Given this list of marker genes NDUFB11 (NADH:ubiquinone oxidoreductase subunit B11), AKAP9, CACNA1S, TMEM43, SLC12A3, CPT2, SCN1B, RYR1, CALM2, SLMAP, GNAI2, SCN2B, CTNNA3, CASQ2, CACNB2, KCNJ8, KCNE3, TBX5, ACTC1, CACNA1C, GYG1, LMOD2, MYOZ2, SEMA3A, TECRL (NCBI Gene Id 253017), TPM1, TANGO2, SCN3B, JPH2, SLC25A20, KCNE5, CSRP3, SCNN1A, SCN10A, MYH7, SCN5A, NAA10, CALM3, DSG2, MYH6, GPD1L, TRDN, MT-CYB, NPPA, ABCC9, MYL2 (myosin light chain 2), HCN4, KCND3, CDH2, KCNJ5, BAG5, PPP1R13L, CACNA2D1, LMNA, CRELD1, ACADVL, CRYAB, PKP2, KCNJ2, TRPM4, HLA-DRB1, RANGRF, DSP, JUP, TTN, RYR2, CALM1, MYZAP, LAMP2, BTNL2, here is a description of the gene set: studied in species Homo sapiens Human Gene Set: HP_VENTRICULAR_TACHYCARDIA Ventricular tachycardia A tachycardia originating in the ventricles characterized by rapid heart rate (over 100 beats per minute) and broad QRS complexes (over 120 ms).